The following is a description of a gene set: Bilateral impairment of the function of the cranial nerves 9-12, which control musculature involved in eating, swallowing, and speech. Pseudobulbar paralysis is characterized clinically by dysarthria, dysphonia, and dysphagia with bifacial paralysis, and may be accompanied by Pseudobulbar behavioral symptoms such as enforced crying and laughing. studied in species Homo sapiens Human Gene Set: HP_PSEUDOBULBAR_PARALYSIS Pseudobulbar paralysis, and this is the list of marker genes: ALS2, NEFH, PI4KA, SOD1, NONO, B4GALNT1, HTRA1, RARS1, FIG4, TGM6, ACTB, SEC31A, SRPX2, PRPH, ZFYVE26, NOTCH3, ALDH18A1, ADGRG1, CYP27A1, DCTN1, NUS1, HMBS